Given this list of marker genes Exo1, Brca1, Rad50, Samhd1, Rbbp8, Zfp365, Nbn, Dynll1, Mre11a, Bard1, here is a description of the gene set: studied in species Mus musculus The 5' to 3' exonucleolytic resection of DNA at the site of a stalled replication fork that contributes to replication fork processing. Mouse Gene Set: GOBP_DNA_STRAND_RESECTION_INVOLVED_IN_REPLICATION_FORK_PROCESSING